Given this list of marker genes GK2, GPAT3, GPD2 (glycerol-3-phosphate dehydrogenase 2), GPAT2, GK5, GPD1, GK, GPD1L, here is a description of the gene set: The chemical reactions and pathways involving glycerol-3-phosphate, a phosphoric monoester of glycerol. species: Homo sapiens Human Gene Set: GOBP_GLYCEROL_3_PHOSPHATE_METABOLIC_PROCESS